Given this list of marker genes C1QA, CFHR3, CFI, CFH, CFHR1, here is a description of the gene set: species: Homo sapiens Concentration of the complement component factor I in the blood circulation below the lower limit of normal. Decreased circulating complement factor I concentration Human Gene Set: HP_DECREASED_CIRCULATING_COMPLEMENT_FACTOR_I_CONCENTRATION